The following is a description of a gene set: from publication Bedogni F, Hevner RF (PMID 34321999) Mouse Gene Set: HEVNER_CORTEX_NEURAL_STEM_CELLS species: Mus musculus Genes selectively expressed by neural stem cells in embryonic day 14.5 mouse telencephalon., and this is the list of marker genes: Slc1a3, Mtarc2, Pbk, Sox1, Vim, Vegfc, Aurka, Melk, Ccnd1 (cyclin D1), Nfatc4, Nr2e1, Aldh9a1, Sox2, Sall3, Sox9